Given this list of marker genes Nmu, Kit, Ptafr, Ghrl, Ptger3, Spx, Ghsr, here is a description of the gene set: species: Mus musculus Mouse Gene Set: GOBP_POSITIVE_REGULATION_OF_GASTRO_INTESTINAL_SYSTEM_SMOOTH_MUSCLE_CONTRACTION Any process that activates or increases the frequency, rate or extent of gastro-intestinal system smooth muscle contraction.